Given this list of marker genes MAPK14, ZCCHC9, MYH9, TFAP4, LMNA (NCBI Gene Id 7816), BMP4, WEE1, MMP1, TP53BP1, ZFP36L1, ITSN1, TNFRSF1A, DDIT4, MN1, AR, ZNF521, TMEM198B, HNMT, ADM, RUNX1, AHR, TFAP2A, ACO1, ENG, FGF7 (fibroblast growth factor 7), RBMS1, ANP32A, IGF1R, RALGDS, CDC25B, IGFBP2 (NCBI Gene Id 3485), ADRA2A, AKR1C1, GAS1, TCF7L2, CEBPD, MARCKS, APOE, USP4, NR3C1, ADH1B, IL6ST, TGFBR3 (NCBI Gene Id 7049), ERCC5, AARS1, FBLN1, NR2F2, ID2, ANAPC1, ACVR2A, here is a description of the gene set: Mechanistic insights to viral replication and pathogenesis generally have come from the analysis of viral gene products, either by studying their biochemical activities and interactions individually or by creating mutant viruses and analyzing their phenotype. Now it is possible to identify and catalog the host cell genes whose mRNA levels change in response to a pathogen. We have used DNA array technology to monitor the level of approximately 6,600 human mRNAs in uninfected as compared with human cytomegalovirus-infected cells. The level of 258 mRNAs changed by a factor of 4 or more before the onset of viral DNA replication. Several of these mRNAs encode gene products that might play key roles in virus-induced pathogenesis, identifying them as intriguing targets for further study. from publication Zhu H, Cong JP, Mamtora G, Gingeras T, Shenk T (PMID 9826724) Down-regulated at 8 h following infection of primary human foreskin fibroblasts with CMV Human Gene Set: ZHU_CMV_8_HR_DN studied in species Homo sapiens